The following is a description of a gene set: species: Mus musculus Any process that modulates the frequency, rate or extent of programmed cell death that occurs in the retina. Mouse Gene Set: GOBP_REGULATION_OF_RETINAL_CELL_PROGRAMMED_CELL_DEATH, and this is the list of marker genes: Tmem215, Bhlhe23, Casp6, Bcl2, Fgf2, Bdnf, Cntf